The following is a description of a gene set: Any process that stops, prevents, or reduces the frequency, rate or extent of the addition of ubiquitin groups to a protein. studied in species Mus musculus Mouse Gene Set: GOBP_NEGATIVE_REGULATION_OF_PROTEIN_UBIQUITINATION, and this is the list of marker genes: Bex1, Cdk5, Spry2, Usp4, Ivns1abp, Gbp4, Rpl5, Limk1, Rpl23, Peli3, Bex3, Gnl3l, Gclc, Spopl, Rpl11, Cdkn2a, Rps7, N4bp1, Psen1, Trim44, Chp1, Mad2l1, Hdac8, Atg5, Fbxo5, U2af2 (U2 small nuclear ribonucleoprotein auxiliary factor (U2AF) 2), Plaa, Cav1, Gps2, Park7, Ufl1, Arrb1, Svbp, Bag5, Per2, Ogt, Pabpn1l, Rasd2, Pinx1, Prkcg, Dnaja1, Marchf7, Ubxn1, Fyn, Usp44, Sox4, Ppia, Tnfaip3, Vps28, Senp2, Adgrb1, Psen2 (NCBI Gene Id 98295), Dysf, Bex2, Cry1, Bag2, Smad7, Prkce, Klhl40, Gtpbp4, Parp10, Cep78, Nxn, Sirt7, Akt1, Bex4, Caml, Sh3rf2, Ttc36, Abl1, Tspo, Wnk1 (NCBI Gene Id 406236), Dtx3l, Prmt3, Arrb2, Isg15, Cep63, Hspa1b, Mad2l2, Sqstm1, Rps3, Minar1, Mtor